Given this list of marker genes H2BC26, EP400, H4C1, UBN1, CDK2, CABIN1, LMNB1, H2BC21, H1-1 (NCBI Gene Id 3024), CCNE1, H2AB1, H2AC7, CDKN1B, H1-3, H2BC1, H2BC3, TP53, H2BC15, H2BC14, ACD (ACD shelterin complex subunit and telomerase recruitment factor), H2AC6, H2AC4, CCNE2, TINF2, MRE11, H1-4, CCNA2, CCNA1, H3-4, H2BC17, ASF1A, HIRA, POT1, H2AX, ATM, H2AC20, H2BC12, H2AC14 (H2A clustered histone 14), RB1, H1-0, HMGA1, TERF2IP, H2BC12L, H2BC9, H2BC11, H2AC18 (NCBI Gene Id 8337), H2BC5, KAT5, H2BC4, CDKN1A (NCBI Gene Id 1026), HMGA2, NBN, RAD50, H2BC13, TERF2, H1-2, H2AZ2, TERF1, H1-5, H2AJ, here is a description of the gene set: Reactive oxygen species (ROS), whose concentration increases in senescent cells due to oncogenic RAS-induced mitochondrial dysfunction or due to environmental stress, cause DNA damage in the form of double strand breaks (DSBs). In addition, persistent cell division fueled by oncogenic signaling leads to replicative exhaustion, manifested in critically short telomeres. Shortened telomeres are no longer able to bind the protective shelterin complex and are recognized as damaged DNA. <p>The evolutionarily conserved MRN complex, consisting of MRE11A (MRE11), RAD50 and NBN (NBS1) subunits, binds DSBs and shortened telomeres that are no longer protected by shelterin. Once bound to the DNA, the MRN complex recruits and activates ATM kinase, leading to phosphorylation of ATM targets, including TP53 (p53). TP53, phosphorylated on serine S15 by ATM, binds the CDKN1A (also known as p21, CIP1 or WAF1) promoter and induces CDKN1A transcription. CDKN1A inhibits the activity of CDK2, leading to G1/S cell cycle arrest.<p>SMURF2 is upregulated in response to telomere attrition in human fibroblasts and induces senecscent phenotype through RB1 and TP53, independently of its role in TGF-beta-1 signaling. The exact mechanism of SMURF2 involvement is senescence has not been elucidated. studied in species Homo sapiens Reactome Pathway: DNA Damage/Telomere Stress Induced Senescence part of: Cellular Senescence